The following is a description of a gene set: Human Gene Set: REACTOME_ADP_SIGNALLING_THROUGH_P2Y_PURINOCEPTOR_12 studied in species Homo sapiens ADP signalling through P2Y purinoceptor 12, and this is the list of marker genes: GNGT2, GNAT3, GNAI1, GNAI3, GNG10, GNAI2, GNB2, P2RY12, GNG12, GNG8, GNG7, GNG13, GNG4, GNB3, GNB5, GNG11, GNGT1, GNG2, GNG3, GNG5, GNB1, GNB4